The following is a description of a gene set: Abnormal renal corticomedullary differentiation Human Gene Set: HP_ABNORMAL_RENAL_CORTICOMEDULLARY_DIFFERENTIATION studied in species Homo sapiens An abnormality of corticomedullary differentiation (CMD) on diagnostic imaging such as magnetic resonance imaging, computer tomography, or sonography. CMD is a difference in the visualization of cortex and medulla., and this is the list of marker genes: BSND, PAX2, ACTN4, DHX16, IFT140, TULP3, NIPBL, DZIP1L, USP18, DCDC2, COQ7, UMOD, PDCD6IP (programmed cell death 6 interacting protein), TSC2, TMEM67, IFNG, CEP290, VPS33B (VPS33B late endosome and lysosome associated), PBX1 (PBX homeobox 1), INVS, CLCN7, H4C3 (H4 clustered histone 3), PKHD1